Given this list of marker genes SRSF4, PPIA, CFL1, RPS8, POLG (NCBI Gene Id 5428), RPL11, PRMT1, DHPS, ATP5PB (NCBI Gene Id 515), EIF3C, NACA, HNRNPU, SLC25A6, KHDRBS1 (NCBI Gene Id 10657), TBCB, RPL27, RPL32, ACTG1, PSMD11, PSME1, RPL14, PCBP1, PSMB4, PSMB2, ZNHIT3 (NCBI Gene Id 9326), TCEA1, RHOA, EIF4H, IK, ATP5MC3, SUMO2, EEF1G, RPSA, RPL4, ATP1B3, RPL29, RPL19, LMNB2, EPRS1, HNRNPD, PSMD8, PSMA1, PFN1, HNRNPL, ATP5F1C, NDUFA12, SRSF9, EIF4B, PSMC3, RPS16, SLC25A3, RPL23, PWP1, SET, RPS5, RACK1, RPL6, APEX1 (NCBI Gene Id 328), PCBP2 (NCBI Gene Id 5094), BUD31, POLR2G, EMD, NCL, CLIC1, RPS7, ILF2, YWHAZ, HSP90AB1, YBX1, NPM1, SNRPD3, UBB, ANP32B, SNRPA, NASP, ATP5F1B, GPS2, NONO, POLR2K, EEF2, EIF3F, DDX39B, RAF1, HNRNPA1, H2AZ1, RPL21, HNRNPM, PPP1CC, CSNK2B, RPL17, SF1, RPL7 (NCBI Gene Id 6129), RPL3, SNRPD2, FUS, SF3B2, PTMA, TRIM28 (tripartite motif containing 28), RPL18, here is a description of the gene set: Neighborhood of CSNK2B studied in species Homo sapiens Neighborhood of CSNK2B casein kinase 2, beta polypeptide in the GCM expression compendium Human Gene Set: GCM_CSNK2B